Given this list of marker genes KBTBD2 (NCBI Gene Id 25948), COX16, OGDH, STUM, SND1-DT, EXTL3, EFCAB14-AS1, FOXJ3, JPT1, RSRP1, PLA2G12A, SLC25A25, PPP1R3D, EN1 (NCBI Gene Id 2019), SAR1B, HEXIM2, GHET1, LARP7, TMEM177, FDX2, TSHB, CAB39L, MRPS27, WSB1, TRAV33, AKR1E2, MIR5091, MCTS1, STX16-NPEPL1, MEIS1, KRTAP3-1, MIR7849, AP3M2, INTS8, SLC2A4RG (NCBI Gene Id 56731), RN7SKP192, ZFAND3-DT, PEX7, EYA3, KLHL21, COX7C, CASC11, ITFG2-AS1, BAZ2A, BRINP3-DT, FARP2 (FERM, ARH/RhoGEF and pleckstrin domain protein 2), OTX1, PROSER1, HARBI1, FBXO46, C2CD3, PRKCSH, IBTK, C2CD5, TBC1D30, RPS11, GSE1, IFI16, ICE2, ASNSD1, ASMTL, OXSM, MIR5188, SNORD113-9, MACC1, SAMD9L, TMEM125, RBMXL1, APOC1, VDAC2, ATF7IP, GNG4, SAFB, IFRD1, LNCATV, RAB34, CXXC1, AP3S2, RPL41, VPS4A, RPL39P40, CRADD, EXOSC8, GPCPD1, MIR1265, WDR83, MIR3926-1, FXYD6-AS1, STT3A, RAD51B, CCDC88C (coiled-coil domain containing 88C), VEPH1, PPP4R1L, SLC1A3, CRYGS, RNY3, DTNA, SMAD1, ATP10B, GDE1 (glycerophosphodiester phosphodiesterase 1), LINC02252, ATF1, IQCG, SPAG9, BMF, RNU1-132P, MED7 (NCBI Gene Id 9443), ZFHX3, MEIS1-AS3, MYT1, SYNE1, MYADM-AS1, CRLF2, ENSG00000287636 (NCBI Gene Id 124901766), SPINK5, NR2F1-AS1, RARG, MARF1, UQCC1, ADARB1, KDM8, ARPC5, LRIG2, ZNF410, PSMD10P2, SNRPE, ISCA2P1, UBR3, SUPT7L, ACTL6A, MYO3A, ZFAND3, RPS29, SPATA24, ATP5MC1, LINC01823, SPRED2, MEF2C-AS1, EFL1, PLBD1, ANXA7, TPD52, MAN2A1-DT, CUX1, PLAAT3, YAP1, ATG12, CD36 (NCBI Gene Id 948), THBS1, PKM, MTMR11, ITPKC (inositol-trisphosphate 3-kinase C), HACD2, RANGRF, ALDH1A2, LINC01354, LINC00992, IKZF2 (NCBI Gene Id 51173), FOXN3-AS1, CLCN3, DET1, RABGGTB, TXN2 (NCBI Gene Id 25828), PMVK, PCBP2, ENSG00000270571, INSM2, RNA5SP323, TBX3, COL17A1, BRD8, CAPN8, LSM10, DDX49, CNPY1, TNPO1 (NCBI Gene Id 3842), NME2P2, GTF2H3, ZNF74, PSMD9, PSMA3-AS1, USPL1, UBE2O, TRIP4, ISY1-RAB43 (ISY1-RAB43 readthrough), CDH11, RN7SL39P, ASH2L, SPRYD4, IFT46, ZNF731P, CACNA1A, MRPS33, BICDL1, HEXIM2-AS1, CHCHD5, NIPSNAP1, PRKACA, PPP2CA, ARMT1, PARD6B, UFSP2, CHD9NB, SEMA4B, FBRS, COX17, SOX2-OT, RPL21P131, ACBD5, LINC01579, GIRGL, DTX4, RPL7P41, TMC1, LINC02707, SRI, PIP5K1C, PSME3, PSMB3, ZNF234, COPS4, RNU6-1158P, NR2F2, FAXDC2, SLC11A2, SLC9A6, ZGRF1, BATF, ARMH4, CEP350, BLOC1S6, DUSP6, MFAP3, RGS17P1 (regulator of G protein signaling 17 pseudogene 1), MYC, ABHD16A, CNOT1 (CCR4-NOT transcription complex subunit 1), TMEM214, BCAS4, NFE2, SEC24C, EXOGP1, RN7SK, PLEC, HOXB7, ZNF282, PRDM2, CCN2, ELP3, RECQL, ASAH2B, RNU6-9, ACYP2, CCDC186, RPS8, MMP11, FTSJ1, ASB3, FEZ2, GPBP1L1, DHRSX, MROH8, SGPP1, UMODL1, GPX2, FMC1-LUC7L2, MEF2C, MALAT1, LINC02343, AP1M1 (adaptor related protein complex 1 subunit mu 1), HNF4A (hepatocyte nuclear factor 4 alpha), PLEKHB1, BBOX1-AS1, FBXL18, COX15, TAF4, AHCYL2, KIF20A, GATA3, INO80B, BAHCC1, NHSL1, ENSG00000269091, TOGARAM2, DACT3, VAMP1, FBXO34-AS1, RIN3, MON1B, RPN2, GMDS, ATF7IP2, WDR45B, DNAH7, MYADM, TBL1X, SPTA1, GATA3-AS1 (GATA3 antisense RNA 1), SFT2D2, SNRPD2 (NCBI Gene Id 6633), TMED1, ODAD3, HABP2, KCNS2, NHEJ1, STAP2, WDPCP, CLK4, ZSCAN31, SNORD118, SEPHS2, PSME2P3, TMF1, HNRNPA1P42, POLR2G, CLN8, SREK1, RSL24D1, ARHGAP32, ELK2AP (ETS transcription factor ELK2A, pseudogene), VWA5A, LINC01972, LINC02015, SNX1, MCRIP1, OR10J2P, SMIM13 (NCBI Gene Id 221710), LARP1B, KRT8, SLAIN2, UTP3, PLEKHA8P1, CEACAM19, BTNL8, SETDB2, SUMO2, ID2-AS1, SLC38A2, FAM227B, CUTC, PATJ, HSDL1, MCC, C11orf21, GUSBP2, VAC14, MPV17L2, PTPRF, SLTM, CLK3, ENSG00000207147, MLPH, MIR548AQ, YY1-DT, NUP155, COQ8B, LPP, CABIN1, ENSG00000283078, SAMD1, CLTC, AGR2, EVI5L, ZNF398, FBXO24, C12orf76, FBXO34, IMPDH1, HAUS5-DT, DMAP1, CISTR, PKD1L2, AKAP1, PHACTR3, LINC01732, PIH1D1, STRIP1, FNIP2, FCHSD1, PARP2, SAFB2, BABAM1, BUB1B, TBX6, SART3, AMMECR1, EIF2AK2, EOGT, KLHL38, ARL14EPP1, CARF, DNAJB2, LSM14B, JTB, GXYLT1, ZNF623, DACT3-AS1, EXOSC5, ADGRF4, SSR4P1, CEP78, NIP7, LATS1, BAIAP2L1, ERGIC1, NUSAP1, KALRN, ROCK1P1, DRG1, DYNC2H1, ARAP1, STPG2, ZNF713, EIF4G3, PRR13, RBBP8, PIGO, HAUS5, RNU7-195P, ZNF213-AS1, ENSG00000222095, LRBA, PLEKHM1, CHD6, SYS1, CHCHD3P1, AP5M1, VPS52, DOP1A, ATG101, ALOXE3, TCF7L2 (transcription factor 7 like 2), MGST3, VPS29, FSTL4, POLR2D, GRPEL2, TANGO6, MIR200CHG, LPXN, BLTP1 (NCBI Gene Id 84162), FAM3B (FAM3 metabolism regulating signaling molecule B), GTF2B, LSM14A, HNRNPA3, SCN2A, ENSG00000249236, THBS4-AS1, RNU6-433P, REG4, CPED1, RNU4-2, RPS18, LRRC23, PATZ1, RPL21P12, COMMD2, EML6, RIF1, MED16, TMOD3, SAMD4B, TATDN1P1, VMP1, MIR644A, P4HB, R3HDM2, PRKCI, SNORD111B, HMGB1, CAPS2 (NCBI Gene Id 84698), CEBPG, CCNQ, UCA1, SLC22A5, PIGO-AS1, LINC02960, CFAP96, ZBTB8OS, MAN2A1, UTS2B, CRPPA-AS1, ENSG00000227706, ERLEC1, TRMT12, LTB4R2, FTCDNL1, ADGRF1, CLIP4, PLA2G4E-AS1, NOSIP, BRINP3, MIR4766 (microRNA 4766), CDC73, SNX8, ATG13, GUSBP1, NFKBIL1, FABP5, MYCL, PRORSD1P, STYK1, PLAC8 (NCBI Gene Id 95621), MRPS23, TMEM62, PLEKHA5, SMIM10L2B, WDR83OS, LAPTM4B, SLC22A17, MAX, ZNF252P, PCTP, LYZ, APOOL (apolipoprotein O like), CA1, SPICE1, KIAA0319, TIPARP, FAM114A2, PPP6R3, ATP6V1G2-DDX39B, PLIN5, EDEM2, PLSCR4, ATPSCKMT, SNAI3-AS1, TPM4, CEP152, NUP107, SCAMP1, INO80, FNBP4, PCLAF, TCF4, CCDC124, MIR6070 (microRNA 6070), GCNT3 (NCBI Gene Id 9245), LRCH4, ABHD2, KDM5A, TSPAN31, MARCHF10, CEP290, EXPH5, AP1M2, FAM13A, INTS14, CCT8, HCG20, PCM1, ABCB8, ISY1, COPE, PNPLA7, CCNP, R3HDML-AS1, EPHA7, NINJ2, SNHG1, TMEM161B, VCPIP1, C1QA, RPL36, GALNT2, LPAR2, SNRNP70, KNL1, H2BC15, CPNE2, COG3, ASB8, NDC1, QPCTL, DNAJC1, SHLD1, LENG1, COL4A2 (collagen type IV alpha 2 chain), SENP2, CFLAR-AS1, RNF44, CCDC159, BNIP2, DARS1-AS1, CSNK1A1, LEPROTL1, DRAIC, CDV3 (CDV3 homolog, NCBI Gene Id 55573), LYSETP1, GCDH, ENSG00000283432, DTWD1, ZNF446, ZFHX2, MIR3646 (microRNA 3646), KIF2A, ANKRD34A, UBQLN1, GFM2, MPND, TENT2, PLEKHH1, CNOT6L, CSTF1, AHI1, ENO3, INO80B-WBP1, ZFAND6, SERPINB9P1, FAM217B, RBBP4, ANO6, CLNK, UTP11, SNORD28, MSI2, SPECC1P1, COG7, ESR1, COPB2, YAE1, SPAST, PCDHB3, TATDN3, AGPAT1 (NCBI Gene Id 84827), TXNP5, VWA8, ZDHHC1, ATP6V1G2, MIOS, MLLT3, LINC01734, ERAP1, DHRS4-AS1, ENSG00000275740, ZIM2-AS1, RIMKLB, BOD1L1, CIAO2A, RN7SL445P, UBE3C, NCOA7 (nuclear receptor coactivator 7), DNAJC16, FREM2, SLC15A2, HSD17B2, TLE4 (NCBI Gene Id 7091), CSNK1G1, ABCC5-AS1, RMND1, TMEM161B-DT, KLHDC9, UBC, OIP5, IKBKB-DT, SACM1L, CLSTN3, ETFDH, SNRNP35, RPP21, SLC35E3, MAP4, HDAC8, NAGLU, TLE6, TMEM238L, CLPX (caseinolytic mitochondrial matrix peptidase chaperone subunit X), ID2, ARID5B, TBP, ZNF609, POLR3G, OIP5-AS1, RNU5B-1, ERCC2, FREM2-AS1, LEKR1, SNIP1, ARFGEF2, SLC24A1, EPB41L4B, ZNF585B, AARS2, ENSG00000200999, RNU6-821P, BMAL1 (basic helix-loop-helix ARNT like 1), TOMM22P6, RNU4-1, ZNHIT3, CEP112, ZIC3, MYLK-AS1, PPP2R5B, ANAPC10, TRIM54, SNORD30, RBM27, DLGAP1-AS2, UBALD2 (NCBI Gene Id 283991), KCTD3, VCP, ZNF689, LINC02984, POC1B, RUNX1, PSKH2, RPL19P14, TUBB4B, TTLL6, KIAA1217, TEDC1, ITFG2, RPL35A, PIK3C2B, CENPN-AS1, JTB-DT, SPATS2L, TTI2, NSL1, RPL3P4, RBBP5, PPP1R13L, GSTA4, LNMICC, TECPR1, ABCG2, COG8, GLIPR1L2, KCNJ15, CREB3L1, ARRDC3, LINC02950, YY1 (YY1 transcription factor), P2RY6, HOXA-AS3, CYP2B7P, PSMB1, PIERCE2, CCT5, EIF4E, ARID4A, STARD10, ENSG00000255314, PPP6R1, GBE1, RAD9B, FAM111A, EHD4, ATPAF1, PREP, HAVCR2, SCAMP5 (NCBI Gene Id 192683), DIXDC1, NSA2, PDCD6, ATG4B, LIMA1, ARHGEF28, ALDH3A2, DCC, LINC02533, RGS6, FMO1, MTFR1, SAPCD2P2, RPS6KA5, VN1R28P, IGLV3-32, CREB1, NOL6, TMEM243, ARHGEF37, RAB5B, GOLT1B, LINC02842, ULBP1, LMO4, IL1R1, BETALINC1, NADK2 (NCBI Gene Id 133686), RPS6KB1, DEDD, ATMIN, RN7SL346P, TMPRSS11F, SLC33A1, ZNF213, KAT5, SEMA4G, BRD10, SYTL3, SMARCD2, NAIF1, ZNF423, ATG5, TAB3, RPL7P30, BTN3A2, CMTM3, PISD, LINC00466, CIDEB, PCBP1-AS1, TMEM161A, RNU5D-1, OPLAH, LINC01132 (NCBI Gene Id 100506810), LINC01701, BLOC1S2 (biogenesis of lysosomal organelles complex 1 subunit 2), OAT, SNORD13, ANKRD13A, FMC1, KIAA0513, LINC02243, C4orf46, KYNU, CCDC137, PIK3CA, ANKHD1 (NCBI Gene Id 79721), ILF2, SLC35E1 (NCBI Gene Id 79939), TMTC3, POC1B-GALNT4, CCT7P2, RPL27A, LRRC37A3, EGR2, PMEL, MTO1, BCKDHA, TESK2, CDK2AP1, SSR1, KATNB1, RNY1, TTC39C, OR1AA1P, DLX2, PSD4, AIP, PSMG3, ANKHD1-EIF4EBP3, PPRC1, MAN2A2 (mannosidase alpha class 2A member 2), MAFA, NT5C3A, PRKAR1A, POU2AF1, KRT18P46, LARS1, DBTP1, HM13, SNORD55, RPL23A, PM20D2, INTS13, HSPD1, EIF2B1, KPNA6, PGP, EFTUD2, PJA2, VPS36, ENSG00000260136, BRI3BP, SLC4A1AP, ANKHD1-DT, LINC02934, ACSS3, UBE2D2, CARD8-AS1, TGFBI, C19orf38, DAGLB, ABCD4, ADGRB3, ZNF263, MBP, SAE1, KYAT3, MIR4659B, HRG-AS1, TUBD1, GCN1, ADGRB3-DT, GARRE1, AURKA, DCTN1, CLIP1, HSPH1, FAM47E, GREB1, ALDH3B2, ENSG00000253986, TMCO6, PTCH1, PRR5, POLR1G, PANK2, MKRN2OS (MKRN2 opposite strand), ATXN7L3B, GSTP1, RPL30P11, SNX12, DOLPP1, STX16, ACBD4, LURAP1L-AS1, ABCG1, SFR1, here is a description of the gene set: Human Gene Set: CUX1_TARGET_GENES species: Homo sapiens Genes containing one or more binding sites for (CUX1) in their promoter regions (TSS -1000,+100 bp) as identified by GTRD version 20.06 ChIP-seq harmonization. from publication Yevshin I, Sharipov R, Kolmykov S, Kondrakhin Y, Kolpakov F (PMID 30445619)